The following is a description of a gene set: Any process that results in a change in state or activity of a cell (in terms of movement, secretion, enzyme production, gene expression, etc.) as a result of a toxic stimulus. Human Gene Set: GOBP_CELLULAR_RESPONSE_TO_TOXIC_SUBSTANCE studied in species Homo sapiens, and this is the list of marker genes: HP, GPX8, RAB40B, GSTT1, FBLN5, CD36, MGST3, RAB29, NNT, HBG1, NFE2L2, TXNDC2, HBM, PRDX6, TPO, PARK7, EPX, SOD2, ADH5, TXNRD1, BMP7, GPX6, MGST2, PTGS2, MTARC2, ALB, PRDX5, KDM3B, CCS, MB, PTGES, GSTZ1, IPCEF1, GCH1, DHFR, CYGB (NCBI Gene Id 124510), HBA2, EDN1, PINK1 (PTEN induced kinase 1), GSTO1, SOD1, CERS1, NQO1, ADH4, SOD3, PTPN13, GPX3, PTGS1, LANCL1, SLC22A2, LPO, PRDX1, S100A9, NXN, AIFM2, GSTM2, DHFRP1, SELENOF (NCBI Gene Id 9403), RDH11, ABCG2, ABTB2, TXNRD2, CDH13, PRXL2A, SELENOS, ABCB6, SESN1, GSTO2, GSTP1, SLC11A1, LTC4S, APOE, SLC39A8, CAT (catalase), FABP1, HBZ, ABCB1, PXDNL, PXDN, ALOX5AP, GPX1, ESD, NOS3, APOM, AQP8, GPX7, TRPA1, TXNDC17 (NCBI Gene Id 84817), GPX5, GSTM1, GSTK1, EDNRA, MT3, TNF, AMBP, RDH12, PIM1, GSTA1, HBG2, ATP7A, MGST1, SELENOT, AKR1A1, GSR, PRKN, SELENOW, OPRD1, KCNC2, HBE1, MTARC1, GPX4 (glutathione peroxidase 4), TXNRD3, TXN, PRDX4, SESN2, FIS1, SLC22A1, HBD, ALDH1A1 (NCBI Gene Id 96075, aldehyde dehydrogenase 1 family member A1), PRDX2, SLC29A4, PRDX3, DUOX2, MPO, UBIAD1, DUOX1, AKR1B10 (NCBI Gene Id 9405), CP (ceruloplasmin), GPX2, SLC22A3, GSTM3 (glutathione S-transferase mu 3), SRXN1, HBQ1, HBA1, HBB, CLIC2, TP53INP1, APOA4